The following is a description of a gene set: from publication Chen Y, Wang X (PMID 31504780) species: Homo sapiens Human Gene Set: MIR3160_5P Genes predicted to be targets of miRBase v22 microRNA hsa-miR-3160-5p in miRDB v6.0 with MirTarget v4 prediction scores > 80 (high confidence targets)., and this is the list of marker genes: OTUD7B, CLIC5, PPM1L, MICAL2, PTPN4, RSPO4, PDGFRL, CLASP2, SENP1, ARID4A, FAM118A, AKAP12, UFL1, KCNK2, KIF3B, SCAI, NEFM, ZFHX3, TRAK2, SIX1, RC3H1, CNOT7, ASMTL, MPDZ, CAMK2N1, PLXNA4, PATE1, PLXNC1 (plexin C1), SLC12A2 (NCBI Gene Id 6558), PFKFB3, BDP1, EPS8, SHISA9, RCOR3, AGO1, TICAM2, MSL3, RASGRF2, SGCZ, ERAP1, ZNF385B, SH3TC2, OXR1, PCSK2, ZNF704, TAFA5 (NCBI Gene Id 25817), PWWP3B, SCN8A, TUB (NCBI Gene Id 7275), RBMS3 (NCBI Gene Id 27303), CSNK2A2, IGSF11, STMND1, SPAG9, PDGFD, SLAMF6, MTREX, CDS2, COPS9, CDK6, TAB3, ELMOD2, WASF1, RFC3, PBX1, ZC3H12C, C1orf141, HLA-DQB1, SAMTOR, KAT2B, BMPR1B (NCBI Gene Id 658), OPCML, SCD (stearoyl-CoA desaturase), ADAM10, NECAP1, CNOT9, SMC4, ADAMTSL1, PTPRK, GNAS, COA5 (cytochrome c oxidase assembly factor 5), TSC22D2, CAPZB (NCBI Gene Id 832), SASH1, CYTH3, GPATCH2L, LMO7, ZEB1, SYNJ2BP, FOXP2, TNFAIP1, VAT1L, SLC24A4, SLC44A1, SCRN3, EXOC5, PDGFRA, CTNND2, DENND10, PPP3CA, RAPGEF1, CDK14, RPRD2, SH3BGRL2, NDUFA10, VIRMA, KALRN, FHOD3, CNTN5, NAALADL2, DSE, PRSS16, PARP11, PROSER2, PHACTR2, TMPRSS15, RSBN1, FNDC9, CREB3L1, PFN2, TRDMT1, SERP1, DPPA3, INSM1, MEGF9, PROX1, KPNA3, DCUN1D3, KCTD4, ZNF573, KITLG, CRKL, GRM1, HYCC2, ATF7IP2, DUSP18, DIP2A, ARID2, GNS, DNAJC13, NTAN1, JRKL, CDHR3, ATP11C, HBEGF, SLC5A3, NEDD9, VIPR1, USP32, SEPTIN3, SLC9B2, ZBTB38, DGKI, FIGN, ZFHX4 (zinc finger homeobox 4), GABPB1, NR4A3, SERINC5, GFRA1, CXCL5, FUT9, CHRM2, CCDC69 (NCBI Gene Id 26112), ZNF236, UBE2B, UNC13C, ONECUT2, SGCD, CACNA1G, RETREG1, LYPD6B, ST7, FAM107B, GLIPR1, VGLL3, RMND5A, STXBP5, NSL1, SIPA1L1, TM9SF3, C1orf43, SPRED1, IGF2BP2, KCTD9, DAAM1, THUMPD1, NWD2, LPAR1, FHL5, NCOA2, NEU3, SFPQ, SGK1, EIF4A2, CXorf38, MEF2C, SPOPL, RPS6KB1, RCBTB2, HCFC1, ABI3BP, INSYN2A, CLDN12, S1PR3, CWC27, TMEM161B, WSB1, TM4SF18, DEPDC4